Given this list of marker genes NAMPT, HAS1, CLEC4D, TGFA (transforming growth factor alpha), CISH, GUSBP3, SEPTIN6, TAOK1, SOCS2, PLAC8, SEMA4C, SLC7A7, PNPLA6, SAMSN1, PLSCR1, PRKAG2-AS2, PFKFB3, LINC00691, BASP1, H2AC14, UBE2B (NCBI Gene Id 7320), CPD, CMIP, FCGR2A (Fc gamma receptor IIa), NAGS, MAP3K4, TNFRSF8, RUNX1, EHBP1L1, STK26, LPP-AS2, CD55, IRS2, H2BC4, ST20-AS1, FCRLB, LTB4R, MCEMP1, MXD1, TRIB1, RIN3, TRAF3IP2, CDA, CD14, SPTLC2, PTPN2, DDIT4, ITGB8 (NCBI Gene Id 3696), STXBP2, PLD1, EMILIN2, IL6-AS1, RAB31, NFKBIZ, ATF7IP, ZC3H12A, LINC00877, ADGRA2, VDR, STEAP1B, YPEL5, SPACA6, SLC41A2, GPR137B, IL2RA, INSIG2, HS3ST3B1, SOS1, DENND3, FIGNL1, TP53INP2 (NCBI Gene Id 58476), CYTIP, RAB27A, CA12, SLC24A4, SESN2, SMPDL3A, SLAMF1, SERPINB9, SLC16A10, PIK3AP1, LILRA1, GALNT6, SLA, H2BC5, S100A9, GK5, CRACD, DUSP22, CCDC69, FANCA, CCM2L, PTGS2, RIPK3 (receptor interacting serine/threonine kinase 3), SLC49A4, PLP2, FJX1, BEST1, ASPHD2, S100A8, IER3, DUSP4, P2RY6, GK, IL4R, SRGAP2, FCGR2C, PNPLA8, CYB5R2, FPR2, NFAT5, TECPR2, HES1, SIPA1L1, S100A12, SLC4A8, CDKN2D, FCGR2B, MEGF9, SOCS3, SOCS1, APH1B, CDC42EP2, NLRC4, CXCL13, FCER1G, BCL11A, CCND3, NFKB2, RYBP, EHD1, DCTN2, GNA15, MYL6B, SYK, GSTA4, FSD1L, TMEM115, IRF4, ADGRE3, TOM1, SERPINB1, ENSG00000274253, SEPTIN10, GNG2, CASP5, IER5, DCAF5, RAB24, SLC25A37 (NCBI Gene Id 55881), CEACAM3, LINC01465, ATP13A3-DT, ANKRD13D, CYP3A5, PTAFR, LIMK2, SOD2, TNIP3, VNN2, ETV3, METRNL, H2AC6, H1-2, PTGES, PLAGL2, IL10RB, MYO1G, GPANK1, TNFRSF1B, N4BP1, KSR1, FPR1, LILRB1, VEGFA, EMP2, SH3PXD2B, RILPL2, CCNE2, NEFH, C5AR1, PLEKHO2, FTH1, ARHGAP19, ELL, LRRC25, LYN, TBC1D30, LILRB3, USF3, AVIL, CYRIA, TRIP10 (NCBI Gene Id 9322), VNN3P, TRIM36, here is a description of the gene set: studied in species Homo sapiens Genes up-regulated in T cells: control versus IL2 stimulation for 6h. Human Gene Set: GSE36888_UNTREATED_VS_IL2_TREATED_TCELL_6H_UP Cytokine-activated STAT proteins dimerize and bind to high-affinity motifs, and N-terminal domain-mediated oligomerization of dimers allows tetramer formation and binding to low-affinity tandem motifs, but the functions of dimers versus tetramers are unknown. We generated Stat5a and Stat5b double knock-in (DKI) N-domain mutant mice that form dimers but not tetramers, identified cytokine-regulated genes whose expression required STAT5 tetramers, and defined consensus motifs for dimers versus tetramers. Whereas Stat5- deficient mice exhibited perinatal lethality, DKI mice were viable, indicating that STAT5 dimers were sufficient for survival. Nevertheless, STAT5 DKI mice had fewer CD4+CD25+ T cells, NK cells, and CD8+ T cells, with impaired cytokine-induced proliferation and homeostatic proliferation of CD8+ T cells. DKI CD8+ T cell proliferation following viral infection was diminished and DKI Treg cells did not efficiently control colitis. Thus, tetramerization of STAT5 is dispensable for survival but is critical for cytokine responses and normal immune function. from publication Lin JX, Li P, Liu D, Jin HT, He J, Ata Ur Rasheed M, Rochman Y, Wang L, Cui K, Liu C, Kelsall BL, Ahmed R, Leonard WJ (PMID 22520852)